The following is a description of a gene set: Human Gene Set: GAZIN_EPIGENETIC_SILENCING_BY_KRAS species: Mus musculus from publication Gazin C, Wajapeyee N, Gobeil S, Virbasius CM, Green MR (PMID 17960246) The conversion of a normal cell to a cancer cell occurs in several steps and typically involves the activation of oncogenes and the inactivation of tumour suppressor and pro-apoptotic genes. In many instances, inactivation of genes critical for cancer development occurs by epigenetic silencing, often involving hypermethylation of CpG-rich promoter regions. It remains to be determined whether silencing occurs by random acquisition of epigenetic marks that confer a selective growth advantage or through a specific pathway initiated by an oncogene. Here we perform a genome-wide RNA interference (RNAi) screen in K-ras-transformed NIH 3T3 cells and identify genes required for Ras-mediated epigenetic silencing of the pro-apoptotic Fas gene. At least nine of these RESEs (Ras epigenetic silencing effectors), including the DNA methyltransferase DNMT1, are directly associated with specific regions of the Fas promoter in K-ras-transformed NIH 3T3 cells but not in untransformed NIH 3T3 cells. RNAi-mediated knockdown of any of the 28 RESEs results in failure to recruit DNMT1 to the Fas promoter, loss of Fas promoter hypermethylation, and derepression of Fas expression. Analysis of five other epigenetically repressed genes indicates that Ras directs the silencing of multiple unrelated genes through a largely common pathway. Last, we show that nine RESEs are required for anchorage-independent growth and tumorigenicity of K-ras-transformed NIH 3T3 cells; these nine genes have not previously been implicated in transformation by Ras. Our results show that Ras-mediated epigenetic silencing occurs through a specific, complex, pathway involving components that are required for maintenance of a fully transformed phenotype. Genes required for epigenetic silencing of FAS by activated KRAS in NIH 3T3 cells, based on RNAi screen., and this is the list of marker genes: NPM2, E2F1, S100Z, PDPK1, CTCF, DNMT1, ZCCHC4, TRIM37, MAP3K9, DOT1L, EID1, EZH2, TRIM66, EED, BMI1, SMYD1, PTK2B, HDAC9, ASF1A, ZNF354B, RCOR2, MRGBP, SIRT6, BAZ2A, MAPK1 (NCBI Gene Id 5594)